The following is a description of a gene set: Any process that increases cell size. Mouse Gene Set: GOBP_POSITIVE_REGULATION_OF_CELL_SIZE species: Mus musculus, and this is the list of marker genes: Kdm6a, Trp73, Rapgef3, Slc26a5, Ret, Ahr, Hsp90aa1, Ogt, Edn1, Cdk4, Akt3, Hsp90ab1, Kdm1a, Rb1cc1, Ep300, Prkd1, Atp7a, Map3k7, Prr16